Given this list of marker genes CDK12, CCNT2, CDK13, SNW1, CCNT1, CDK9, RB1, CCNK, here is a description of the gene set: Human Gene Set: GOCC_CYCLIN_CDK_POSITIVE_TRANSCRIPTION_ELONGATION_FACTOR_COMPLEX studied in species Homo sapiens A transcription elongation factor complex that facilitates the transition from abortive to productive elongation by phosphorylating the CTD domain of the large subunit of DNA-directed RNA polymerase II, holoenzyme. Contains a cyclin and a cyclin-dependent protein kinase catalytic subunit.